Given this list of marker genes KMT5A, SYCP2, SUSD2 (NCBI Gene Id 56241), INHBA, VPS4B (NCBI Gene Id 9525), KNTC1, ZMPSTE24, CDKN2A, SCAND3, CDKL4, SMARCE1, RMI1, ENSA, TAF10, BCCIP, DDX12P, EFHC1, RCC2, E2F1, SKA1, TIPRL, SGO2, CETN1, ATF5, WAC, LIG1, TP73, CHMP2A, MELK, ZBED3, ZFYVE19, RAB11FIP3, BCL7B, POLA1, IRF1, CALM1, PPP2CA, MOK, FAP, ENSG00000266560, FBXW11, LIN37, ENKD1, CCNG1, SETD2, CSNK1D, SUN1, CEP44, UHMK1 (U2AF homology motif kinase 1), KNL1, MTMR3, NUPR1, AMBRA1, TADA3, FAM9A, CEP68, CCDC61, MAPK12, NEK6, TOP6BL, BRD7, CDK17, DIS3L2, UVRAG, MYBL1, RNF20, NFE2L1, HUS1, RPRD1B, PARD6G, RPL24, HGF, DPF2, TTI1, NUMA1, MIR208A, AATF, GIGYF2, PPP3CA, PIAS1, CDC25B, TRIM39, SETMAR, DYNLT1, WAPL, CENPS, RRM2, SEPTIN7, NFIB, SH2B1, BIRC3, APPL2, MIR451A (NCBI Gene Id 574411), CDC14B, DDX3X, EXOC5, SPRY2, DDIT3, SERPINE1, RAB35, MAGEA5P, MAP4, FBXW5, BLM, STAG3, FAM9C, PPP1R12A, SIRT1, TEX19, PIWIL3, MEN1, KLHL18, AKAP8L, ZZZ3, ID4, ABL1, MIR638, NPR2, CDKN2D, CTDSP1, STK33, OR1A2, CCNG2, DIAPH3, DSN1 (DSN1 component of MIS12 kinetochore complex), ASAH2, INCENP, PRCC, RAD51AP1, TUBA1C, MEI1, RAB11FIP4, RHNO1, RINT1, TRIM75, GADD45G, SND1, MAP3K11, PPP2R5D, HOXD10, GMNN (NCBI Gene Id 51053), TRRAP, TGFBR1, ZPR1, AXIN2, DBF4, SPDYA, NAT10, AICDA, OVOL1, TUBGCP5, PLK3, IQGAP3 (IQ motif containing GTPase activating protein 3), CDKL3, MIR515-1, KIFC1, GOLGA2, CDCA8, NSL1, DYNLT3, MAPRE3, CCNC, CDC25A, EXOC3, GPER1, TIMELESS, PPM1A, CCNE2, PPP2R2A, CDK8 (NCBI Gene Id 1024), NR4A1, EPC1 (enhancer of polycomb homolog 1), PLEC, RNF2, DBF4B, RNF112, FOXJ3, ABRAXAS1, SEPTIN3, CSNK2A2, TUBB6, PTCH1, CDKN2B, NUGGC, PRKAG2, CENPO, PPP2CB, EML1, C9orf78, FOXG1, CCNI, RUVBL1, IQGAP1, UPF1, CENPT, GPR132 (G protein-coupled receptor 132), PABIR1, SHOC1, DDX4, HSP90AB1 (NCBI Gene Id 3326), CDC26, SPHK1, PKD2, RAB6C, CENPJ, FAM107A, CTCF, NIPBL, CEP295, PKIA, ZNF830, RAD51C, FOXM1, BCL6, PBK, NEDD1, INO80E, STAT5A, TUBA1B (tubulin alpha 1b), BRCA1, FMN2, TACC1, GAS1, PBX1, PPP2R3B, UNC119, SKP2, SHCBP1L (SHC binding and spindle associated 1 like), HJURP, CENPV, RB1, NLRP2B, EXOC6, SMC3, EDN1, NEK9, IL1A, MEAF6, ING2, CHMP3, CCDC8, STIL, RAD17, OSGIN2, CEP63, TTYH1, PDCD6IP, RAD21L1, CHEK1, TRAPPC12, ZCWPW1, TRIAP1, CIAO2B, CGRRF1, PPM1G, CEP85, CHMP7, MAPK14, TK1, RASSF1, TAS1R2, PARD6B, TUBG2, RAD50, PRKAG1, AKAP8, CDK15, SLX4, ZWILCH, REDIC1, SIK1, RGCC, OBSL1, MYH10, BIRC8, CDK6, MIR892B, JADE3, MIR29C, IQGAP2, IPO5, BMP7, LGMN, OR2A4, NCAPD3, ABCB1, PUM1, RTF2, IFFO1, CDK9, SMARCA2, RSPH1, CIB1, FGFR2, CGREF1, CENPF, SKA3 (spindle and kinetochore associated complex subunit 3), SMC5, RFWD3, EIF4G1 (NCBI Gene Id 1981), TMEM14B, PKP4, USP33, E2F8, POLE, ZNF365, TAL1, FAM83D, GIPC1, TUBB1, NANOS2, PTPRK, PRDM9, CENPW, SLC6A4, BBS4, TLK2, TRIM37, ANKFN1, ACTL6B, HTT, BUB1B, KCTD19, MN1, BANF1, ACTR8, MIR15A, CTDNEP1, MME, REEP4, VCP, BOLL, CHTF8, GPNMB, RHEB, TXLNG, BCR, CUL4A, DMAP1, SPC25, HECW2, CCNJ, PLSCR1, NABP2, PIN1, INTS13, TLE6, CDC45, MSH6, ADAM17, PPP2R1B, PSMD10, PIM3, MORF4L2, USP50, BABAM1, CHMP4B, MTA3, CCSAP, EGFR, POGZ, CYP1A1, PAF1, TRIP13, DDR2, RPA3 (NCBI Gene Id 6119), KLHDC3, ZNRD2, PHF10, BCL2L11, ANKLE1 (ankyrin repeat and LEM domain containing 1), NLE1, MDM1, OVOL2, ATR, UBE2E2, WNT5A, LIN9, TAOK3, MIR520H, ROPN1B, RACGAP1, HAUS6, DNM2, HES1, KIF11, JADE2, TUBB, FOXE3, LIMK2, CDK13, CASP3, EXOC4, EXOC2, USP44, SPICE1, PPP2R1A, INS, WDR12, CALR, NPM2, HTRA2, RNASEH2B, NSMCE2, ERCC4, HAUS2, EIF2AK4, CDC7, PPP2R5C, XRCC3, PKP3, APBB1, CHMP4A, ACTR3, METTL3 (methyltransferase 3, N6-adenosine-methyltransferase complex catalytic subunit), PES1, AURKB, EML3, TTI2, PIWIL1, MSH5, PAGR1, MBIP, HORMAD1, RDX, CDKN1C, KCNH5, LLGL2, C1orf146, BRSK2, WNK1, GRK5, PKHD1, RRM2B (NCBI Gene Id 50484), MARK3, CENPE, KIF4B, ZWINT (NCBI Gene Id 11130), SMARCD3, DTL, CENPQ, ING3, SRPK2, BIRC7, CABLES2, CAPN3 (calpain 3), UXT, CROCC, CCNE1, E2F7, P3H4, RPRM, FHL1, TOPBP1, TRNP1, RRS1, MTCL1, NSFL1C, BIN1, WDR5, TTC28, WBP2NL, CCNB1, ATAD5, ANXA1, PPP5C, ZNF16, MIR214, SAPCD2, MARK4, MUC1, MASTL, KIF18B (kinesin family member 18B), OPN1MW, DLGAP5, DOT1L, MIR200B, TEX15, KHDRBS1, EPS8, ILK, CCNY, NEK11, PINX1 (NCBI Gene Id 91819), SLFN11, FIRRM, CHAMP1, FANCA, PHACTR4, CECR2, STAMBP, PIWIL4, PTEN, CENPM, PIWIL2, RBL1, RECQL5, CKS1B, CEP76, MAP9, PAFAH1B1, CDC14A, TDRKH, TP53BP1, CDC14C, TELO2, TOM1L1, FBXO6, AKT2, SPAG5, KLHDC8B, NDEL1, PPME1, ID2, PRR19, TUBGCP2, SKIL, PTTG3P, BRD4, TPD52L1, CCL2, NF2, SOX9, TBRG1, CYP27B1, DMC1, EME1, UBXN2B, WRAP73 (WD repeat containing, antisense to TP73), RNF167, PPP1CC, MITD1, MIR372, TM4SF5, TTLL12, PHOX2B, DEUP1, IGF1 (NCBI Gene Id 3479), TERB2 (telomere repeat binding bouquet formation protein 2), ACTB, ERCC3, BTBD18, CENPC, SPDL1 (spindle apparatus coiled-coil protein 1), MCM2, PAXIP1, DGKZ, APP, ERCC6, ZNF324, MED1, SPATA22, CCDC42, RPS27L, ACTR2, STAT3, USP2, ARID1A, TICRR, DCTN3, CDC16, MIIP, SIRT2, TARDBP, UBA3, HSPA1A, USP51, CDK2, IPO7, EP400, CDK12, MCM3, STOX1, ORC4, HAUS5, INSM2, PHGDH, AFAP1L2, DDB1, VPS4A, TUBG1, PIK3C3, RAE1, SYCP1, E4F1 (E4F transcription factor 1), UBE2C, VASH1, BRIP1, SOX2, ZNF541, SEPTIN10, FEM1B, LATS2, NEK4, ERCC1, SSTR5 (NCBI Gene Id 6755), FAM110A, MBTPS1, SIRT7, SEPTIN11, TP53INP1, MAJIN, SMIM22, NAA10, UBE2A, SENP6, TERF1, CHMP4C, DRD2, ESX1, CHMP5, PLK5, HECA, AGO4, CHFR, TEX12, MORF4L1, CDK5, UCHL5, RBM38, TBCE, SASS6 (NCBI Gene Id 163786), HNRNPU, RHOA, BOD1 (NCBI Gene Id 91272), MCMDC2, ODF2, ATP2B4, KIF3B, LYN, GATA6, NR3C1, KIF14, USP16, MEIOSIN, TBCD, GMNC (NCBI Gene Id 652527), WASL, MLH3, SON, PIK3R4, MYB, LRP5, CFL1, DAB2IP, BROX, INPPL1, ROMO1, EXOC1, SHB, RBM7, SMC6, CLASP2, TERT, FIGNL1, BRINP1, GEN1, ITGB3BP, NSUN2, EDNRA, CKAP5, NUPR2, MCMBP, RAD18, LSM10, ZNF655, SENP2, DNA2, FBXW7, NLRP5, MEI4, CLIP1, MIR137, NIN (ninein), CCNL1, MACROH2A1, PAX6, PPP1R9B, ARID2, FGF8, KIAA0753, TEX11, CIT, PRNP, FNTB, ANAPC10, NEUROG1, CHMP1B, LZTS2, RBM14, MCM4, BRCA2, MLH1, POLDIP2, CIAO2A, CDK10, TACC2, PDE3A, CEP135, EPM2A, TRIM32, MRNIP, ECRG4, DNMT3L, CDC27, CCND1, BRCC3, TENT5B, PRKCA, KIAA1614, MZT1, TACC3, CCNF, PUM2, PML, TUBD1, HUS1B, INIP (INTS3 and NABP interacting protein), RAB24, CUL2, PPP1R10, EREG, DDX11L8, ANKRD31, GADD45B, MIR424, GNAI1, MEPCE, ZFP42, SYCE1L, TGFB1, EIF4EBP1, OOEP, KAT5, HAUS1, BAX, KATNB1, BRINP2, ITGB1 (NCBI Gene Id 3688), GEM, LEF1, RPA1, SPTBN1, PDE4DIP, SEPTIN6, GIT1, NCAPG2, RRM1, PLCG2, EXOC7, OPN1MW2, MAP2K6, YTHDC2, TAF6, MYO16, MIR134, KIF22, TADA2A, DDX11, PRC1, BUB1, MAEA, HEPACAM2, HIPK2, FBXO5, RTKN, USP17L2, NAE1, TRIM35, BRDT, PHF13, AURKA, TUBA1A, TFDP2, ZSCAN21, TFDP1, MUS81, ADCYAP1, SSX2IP, DMRTC2, ZFP36L2 (ZFP36 ring finger protein like 2), PSRC1, FANCM, CDK4, YY1, BEX2, TUBA3D, SLC25A31, CDK1, DACT1, MBTD1, ANKRD17, BID, CCNH, DLG1, MKI67, SLC39A5, GTPBP4, GLI1, MIR21, LFNG, CSPP1, BCAS2, PKN2, ZFYVE26, CCNK, ERCC2, HBP1, WNT10B, USP26, OPN1LW, CTC1, ANLN, TMSB4X, TUBB3, BTRC, MDM4, MDC1, CDC20, JUNB, PIM2, DONSON, SMARCD2, TSC1, ASCL1, CEP55, TUBA8, UBE2B, RAD9A, CHORDC1, CLASP1, SNX33, NDP, EXD1, CCDC69, MIR15B, SMC1A (NCBI Gene Id 8243), STRADA, INSM1, SFN, DR1, GPR15LG, IER3, SPART, TUBGCP3, CHMP6, OFD1, MAU2, NUDT6, ASPM, CDK5RAP3, TNF, EVI2B, CCNA2, SYF2, NANOS3, BCAT1, UHRF1, RAD51, RANBP1, LSM14B, ANGEL2, RAD21, CCAR2, CRLF3, C14orf39, PRKDC, KNSTRN, KIF23, AURKC, YY1AP1, KAT7, MND1, MYBBP1A, PPP1R15A, MCRS1, HAUS4, SMC2, EXOC8, MDM2, NUDC, MIR362, KASH5, MX2, TOP2A, INO80C, SPC24, RHOB, SOX15, MIR873, DTX3L, NCAPG, CLOCK, PDXP, MIR221 (microRNA 221), COPS5, HRAS, RPA4, SMARCA4, ANKRD53, BCL7C, INO80D, STK35, REEP3, RNF40, POC1A, RANGRF, MTMR4, ECT2, TAOK1 (NCBI Gene Id 80214), PTPN3, FOXO4, HDAC3, MIR26A1, TGM1 (NCBI Gene Id 7051), PPP1R13B (protein phosphatase 1 regulatory subunit 13B), NCAPD2, TUBA3C, PMF1, ACTL6A, CDC6, TFAP4, MEIOC, TESMIN, NCAPH, BCL2L1, PROX1, MRGBP, MIR30C2, CCNP (cyclin P), MCIDAS, EXO1, DDIAS, SMC4 (structural maintenance of chromosomes 4), TOM1L2, STAT5B, KIF20B, WNT16, PTK6, BIRC6, SIPA1, ANAPC5 (NCBI Gene Id 51433), CDK5RAP1, MMS19, GJA1, MIR495 (microRNA 495), LILRB1, USP29, SPRY1, MECOM, RBL2, CLTCL1, H2BW1, MCPH1, SAC3D1, CCPG1, TOP3B, WDR90 (NCBI Gene Id 64488), CEP120, SLF2, TDRD12 (tudor domain containing 12), KAT2B (NCBI Gene Id 8850), MSH4, DCTN6, KMT2E, EZH2, CUL5, MTCL2, BMAL1, RXFP3, RIOK2, TRIM36, NR2E1, CHMP1A, INTS7 (NCBI Gene Id 25896), PPM1D, CDC5L, MRE11, SLC25A5, LATS1, SYCE1, SFPQ (NCBI Gene Id 6421), REC8, XIAP, IFNW1, CUL3, TSG101, TTN, RAD54L, PLD6, INHA, ABRAXAS2, CCDC102B, LMNA, FOXA1, CDK14, IK, ARPP19, TENT4A, CEP97, BNIP2, AURKAIP1, CCNJL, STRA8, SMARCA5, CEP126, CDKL2, YEATS2, IST1, SIX3, PSME3, MSX1, ARHGEF10, PSMA8, DUSP3, RGS14, STAG1, TAF2, CENPU, BAP1, PRPF40A, CITED2, PRAP1, HOXC9, CTBP1, MBLAC1, MIR29A, TUBGCP6, ACTR5, SMARCC2, HAUS8 (HAUS augmin like complex subunit 8), RHOC, MARF1, BTG4, TMOD3, SEPTIN14, PLRG1, ATM, ARF6, ARL8B, SKA2, MNAT1, PRMT2, H1-8, PDGFB, PLK1, CDK7, TBRG4, ANAPC13, BIRC2, MAD2L1BP, CLTC, PPP2R2D (NCBI Gene Id 55844), TP53, PDIK1L, LIF, RPTOR, INSR, YEATS4, CRNN, WRN, AUNIP, NBN, BABAM2, MAGEA4, MNS1, CENPI, MYC, BTC, KLF11, MOV10L1, CDK16 (cyclin dependent kinase 16), THAP1 (THAP domain containing 1), LSM11, NEK10, USP22, MIR193A, MAD2L2 (NCBI Gene Id 10459), NTMT1, FBXO4, PLA2R1, CDK20, CNTROB, PRKAG3, LCMT1, NUP214, DPF3, NEK2 (NCBI Gene Id 4751), RNF4, NABP1, MEIOB, ENTR1, APC, CRY1, ANAPC7, TBX2, ORC1 (NCBI Gene Id 4998), BECN1, USP9X, HAUS7, ESCO1, THAP5, FLNA, WDHD1, NEK7, MCM6, CCNA1, FOXJ2, PIBF1, ARL2, SMOC2 (SPARC related modular calcium binding 2), SYCE3, SMARCB1, HSF1, BTN2A2, HSF5, SUN2, AAAS, ZC3H12D, MIR133A1, ETAA1, SNX18, PHF8, PRKACA, PTTG2, MTBP, MLF1, KLHL13 (kelch like family member 13), MAP3K7, DUSP13B, MBTPS2, PDS5B, PCNT, BMP4, CYLD, ETS1, MISP, UBB, MEIKIN, WASHC5, UBE2L3, AZI2, IHO1, TSC2, HSF2BP, SEPTIN5, BOP1, FGF2, SETDB2, KLF4, RIPOR2, PRKCB, CHD3, CALM2, PER2, MYH14, NOX5, DAZL, RPS6KB1, BRINP3, CDCA5, NANOGP8, TREX1, GSPT1, CEP72, CDC25C, SVIL, MOS, MAP10, CDC73, NUBP1, PCNA, CCP110, ALOX15B, H2AX, CDT1, SEPTIN8, MIR19B1, RACK1, RNF212B, CAMSAP3, SDCBP, BIN3, BRD8, XRCC2, NME6 (NCBI Gene Id 10201), TPRA1, BRME1, BUB3, MSH2, ANAPC4, KIF2B, FBXO43 (NCBI Gene Id 286151), NDC80, GAS2, KANK2, ARF1, UTP14C, NR4A3 (NCBI Gene Id 8013), VRK1, MAP3K20 (NCBI Gene Id 51784), CDC23, CTNNB1, NUSAP1, C2CD3, FEN1, POC5, ZW10, CXCR5, GFI1B, TUBGCP4, SEPTIN12, HSPA1B, CEP131, SGF29 (SAGA complex associated factor 29), E2F2, CCNB3, CUL9, SRPK1, SPAST, ROCK1, CDKN1A, MEIS2, CCNI2, EXOC6B, RPL23, CKS2, DUSP1, BCL7A, CENPA, NOLC1, ANAPC2, KIF2C, PHB2, HDAC8 (histone deacetylase 8), TPX2, TUBB8, CSNK2A3, FKBP6, TUBB2A, CALM3, SEPTIN9, NDC1, MIR10A, MIR26B, MRFAP1L2, PKMYT1, GBF1, CENPX, TTC19, BMP2, MIR133B, PHIP, RAN, ZBTB17, PRDM11, ACVR1, SEH1L, TP53BP2, CCDC57, USP8, MYOG, M1AP, DRD3, ANK3, INCA1, MIR503, TPPP, CENPK, IL1B, TGFB2, TUBA3E, CEP250, TRIM21, HCFC1, SCRIB, KIF2A, KIF3A, PPP2R5B, TP53I13, KIZ, ATRIP, PARD6A, CREB3, NRDE2, CDK18, POC1B, ZNF207, SMPD3, CDK5RAP2, HLA-G, HEPACAM, C4orf19, CDKN1B, SEPTIN1, FBXO31, UBE2I, BAZ1B, CDK5R1, WNT4, TUBE1, CETN2, SMC1B, TSPYL2, HPGD, FZD3, FAM9B, MIR520A, GNB1L, RBM46, DYRK3, TUBB2B, PTPRC, BEX4, JTB, RAD1, UHRF2, MIR195, KIF25, DYNC1LI1, CACNB4, NDE1, PBRM1, RTTN, LEP, NCAPH2, CEP295NL, ADAMTS1, MAPRE1, STMN1, ATXN10, RAB11A, KIF15, RBBP8, MNT, TOP1, FGFR1, CDCA2, ZNHIT1, CENPL, RAD23A, RRP8, PTENP1-AS, RAD54B, CTDSP2, SLF1, MYO19, NHERF1, BRSK1, GPR3, REC114, RPS3 (NCBI Gene Id 6188), INO80B, CDC42, SEPTIN2, PARP3, DPF1, GINS3, TERF2, CABLES1, DAPK3, TBX3, SMARCD1, GTF2B, CCNL2, SDE2, DMRT1, BCL2, OIP5, DCDC1, NKX3-1, HEXIM2, SH3GLB1, DSCC1, WIZ, ITGB1BP2, ROCK2, LLGL1, CNTD1, TPR, JADE1, PRKCE, KIF4A, E2F3, TBX20, SLC16A1, RNF212, FBXL15, GPSM2, HORMAD2, SGO1, RHOU, TGFA, ASZ1, USP37, ALKBH4, NES, MRGPRX2, CDK11A, SPO11, EIF4E, NAA50, LIPA, UIMC1, BARD1, NUP62, IGF2, RMDN1, EIF4G2, CDKL5, ZNF268, PIM1, CTDP1, TCF3, TFPT, MAD2L1, PTPN11, ZFP36L1, RAD51D, SGSM3, PSME1, CHMP2B, TEX14, PTPA, SYCE2, MYH9, TDRD1, PRICKLE1, STK38, CDKN2C, KCNA5, SPIN1, SPIRE1, FOXN3, CAMK2A, FGF10, ANAPC16, ZNF503, AIF1, RPA2, ZNRF4, ING4, TMEM8B (NCBI Gene Id 92973), HAUS3, MAD1L1, MIR222, KAT14, PLK2, JUND (JunD proto-oncogene, AP-1 transcription factor subunit), WEE2, EPC2, PLK4, SBDS, TTK, LPIN1, PDGFRB, UBE2S, CENATAC, EGF, POU4F1, CYP26B1, MIR16-1, MAPRE2, WEE1, UFL1, ANAPC15, HFM1, ZBTB49, CDK11B, WDR76, APBB2, CCND2, NAA60, PRMT5, KLHL22, CDC34, FES, CCDC15, PARP9, UBR2, NFIA, CCND3, DCUN1D3, DCAF13, TSC22D2 (TSC22 domain family member 2), ECD, MIR29B1, DCTN1, WDR62, MAP1S, WDR6, NUDT16, NPPC, ANXA11, PKD1, FOXC1, PSME2, PLAGL1, ASNS, CCNO, PSMG2 (proteasome assembly chaperone 2), CCNQ, ANAPC11, PPP1R35, CUL7, VPS72, ANKLE2, CUL4B, MADD (MAP kinase activating death domain), CEP152, FANCD2, CSNK2A1, DACH1, TTL, LSM14A, SMARCC1, TOP3A, RAD9B, USH1C, CATSPERZ (catsper channel auxiliary subunit zeta), RMI2, PPP6C, SNX9, MAEL, MIR34A, TOP2B, IL10, ACVR1B, DBX2, CCDC66, RAD51B (NCBI Gene Id 5890), ALMS1, INO80, TUBB4B, SLC2A8, CAV2, LRP6, MIR590, RTEL1, BORA, TUBB8B, SMARCAD1, EHMT2, ARL8A, JUN, CIAO1, PDS5A, MIS12, CSAG1, KDM8, EML4, CHMP4BP1, TUBAL3, STXBP4, ZNF703, STARD9, DUX4, PSMC3IP, SYCP3 (synaptonemal complex protein 3), ANKK1, PRP4K, L3MBTL1, SPIRE2, LUZP1, TAF1, HASPIN (histone H3 associated protein kinase), DYNC1H1, AFG2B, EPGN, ESPL1, ESCO2, TIPIN, PRDM5, PRR11, TDRD9, TLK1, NPAT, KLHL9 (kelch like family member 9), INTS3, RPS15A, TAS2R13, BAG6, TAOK2, RARA, GADD45A, MSX2 (NCBI Gene Id 8053), BAK1, TRIM71, PCLAF, FBXL7, ADARB1, MIR199A1, NFRKB, KIF18A, DRG1, STAG2, AKT1, RIOK3, NUDT15, RUNX3, PTTG1, CUL1, APPL1, KIF20A, CPSF3, YWHAE, RPL10L, EME2, YTHDF2, BTG3, NEK3, CLSPN, CDK2AP2, DDRGK1, KIF13A, USP28 (NCBI Gene Id 57646), KLHL21, ZNF318, PTPN6, EDN3, TUBB4A, TUBA4A, PCM1, CDKN3, MYBL2, FBXO30, PSMD13, CCNB2, XPC, RPS6KA2, NUP43, ATF2, NPM1, HMGA2, XPO1, C10orf90, KPNB1, TFDP3, NUF2, FZR1, CTDSPL, RASA1, TERB1, PLCB1, RFPL1, RUVBL2, SLC26A8, FBXO7, NUP37, SUV39H1, CENPP, TP63 (tumor protein p63), TMEM67, SFRP1, GINS1, CENPH, CCNB1IP1, NOP53, BIRC5 (baculoviral IAP repeat containing 5), HINFP, UBD, ARID1B, CKAP2, CEBPA, AHCTF1, SUGT1, SIN3A, USP19, ANAPC1, GATA3, GPSM1, ING5, MIS18A, CACUL1, NCOR1, TAF1L, CD28, MIR519D, CDK19, CHEK2, PRPF19, SDCCAG8, RCC1 (regulator of chromosome condensation 1), CDK3, ARL3, SEPTIN4, AVEN, ATRX, CDKL1, STK11, KAT2A, HSPA2, FSD1, HOXA13, CEP192, EZR, CENPN, TNKS, MAPK15, CETN3, DCTN2, FZD9, TCIM, CNTLN, C6orf89 (chromosome 6 open reading frame 89), here is a description of the gene set: Human Gene Set: GOBP_CELL_CYCLE studied in species Homo sapiens The progression of biochemical and morphological phases and events that occur in a cell during successive cell replication or nuclear replication events. Canonically, the cell cycle comprises the replication and segregation of genetic material followed by the division of the cell, but in endocycles or syncytial cells nuclear replication or nuclear division may not be followed by cell division.